The following is a description of a gene set: from publication Koinuma K, Yamashita Y, Liu W, Hatanaka H, Kurashina K, Wada T, Takada S, Kaneda R, Choi YL, Fujiwara SI, Miyakura Y, Nagai H, Mano H (PMID 16247484) Genes up-regulated in colorectal carcinoma samples positive for MSI (microsatellite instability) compared to the MSI negative ones. species: Homo sapiens Mutation or epigenetic silencing of mismatch repair genes, such as MLH1 and MSH2, results in microsatellite instability (MSI) in the genome of a subset of colorectal carcinomas (CRCs). However, little is yet known of genes that directly contribute to tumor formation in such cancers. To characterize MSI-dependent changes in gene expression, we have now compared transcriptomes between fresh CRC specimens positive or negative for MSI (n=10 for each) with the use of high-density oligonucleotide microarrays harboring >44,000 probe sets. Correspondence analysis of the expression patterns of isolated MSI-associated genes revealed that the transcriptome of MSI+ CRCs is clearly distinct from that of MSI- CRCs. Such MSI-associated genes included that for AXIN2, an important component of the WNT signaling pathway. AXIN2 was silenced, apparently as a result of extensive methylation of its promoter region, specifically in MSI+ CRC specimens. Forced expression of AXIN2, either by treatment with 5'-azacytidine or by transfection with AXIN2 cDNA, resulted in rapid cell death in an MSI+ CRC cell line. These data indicate that epigenetic silencing of AXIN2 is specifically associated with carcinogenesis in MSI+ CRCs. Human Gene Set: KOINUMA_COLON_CANCER_MSI_UP, and this is the list of marker genes: PSMB5, CXCL9 (C-X-C motif chemokine ligand 9), RPL22L1, FBXL16, CTNNB1, LAP3, NCAPG, ERH, CD109, ANP32E, TYMS, HOXC6, TPBG, HNRNPL, HLA-DMB, CXCL10